Given this list of marker genes B4GALT6, SAT1, EID2, ZBTB20, MS4A1 (NCBI Gene Id 931), RNF125, IRS2, ZBTB10, RECK (NCBI Gene Id 8434), CCND2, SERPINB1, RAB20, SARAF, AK7, KLF7, NRIP1, HS1BP3, RRAS2, SPP1, CTSV, SLC7A11, KLF6, XIST, CD69, AIG1, PTPN22 (protein tyrosine phosphatase non-receptor type 22), SOAT1, EGLN3, TRIM34, RGS1, KCNQ1OT1, H4C8, here is a description of the gene set: Genes from cluster 2: down-regulated in group C of tumors arising from overexpression of BCL2L1 and MYC in plasma cells. Human Gene Set: BOYLAN_MULTIPLE_MYELOMA_C_CLUSTER_DN studied in species Mus musculus from publication Boylan KL, Gosse MA, Staggs SE, Janz S, Grindle S, Kansas GS, Van Ness BG (PMID 17483317) Multiple myeloma is an incurable plasma cell malignancy for which existing animal models are limited. We have previously shown that the targeted expression of the transgenes c-Myc and Bcl-X(L) in murine plasma cells produces malignancy that displays features of human myeloma, such as localization of tumor cells to the bone marrow and lytic bone lesions. We have isolated and characterized in vitro cultures and adoptive transfers of tumors from Bcl-xl/Myc transgenic mice. Tumors have a plasmablastic morphology and variable expression of CD138, CD45, CD38, and CD19. Spectral karyotyping analysis of metaphase chromosomes from primary tumor cell cultures shows that the Bcl-xl/Myc tumors contain a variety of chromosomal abnormalities, including trisomies, translocations, and deletions. The most frequently aberrant chromosomes are 12 and 16. Three sites for recurring translocations were also identified on chromosomes 4D, 12F, and 16C. Gene expression profiling was used to identify differences in gene expression between tumor cells and normal plasma cells (NPC) and to cluster the tumors into two groups (tumor groups C and D), with distinct gene expression profiles. Four hundred and ninety-five genes were significantly different between both tumor groups and NPCs, whereas genes were uniquely different from NPCs in tumor group C and genes were uniquely different from NPCs in tumor group D. Similar to human myeloma, the cyclin D genes are differentially dysregulated in the mouse tumor groups. These data suggest the Bcl-xl/Myc tumors are similar to a subset of plasmablastic human myelomas and provide insight into the specific genes and pathways underlying the human disease.